The following is a description of a gene set: from publication Cui A, Huang T, Li S, Ma A, Pérez JL, Sander C, Keskin DB, Wu CJ, Fraenkel E, Hacohen N (PMID 38057668) Mouse Gene Set: CUI_TREG_IL18_RESPONSE_UP Cytokines mediate cell-cell communication in the immune system and represent important therapeutic targets. A myriad of studies have highlighted their central role in immune function, yet we lack a global view of the cellular responses of each immune cell type to each cytokine. To address this gap, the authors created the Immune Dictionary, a compendium of single-cell transcriptomic profiles of more than 17 immune cell types in response to each of 86 cytokines (>1,400 cytokine-cell type combinations) in mouse lymph nodes in vivo. A cytokine-centric view of the dictionary revealed that most cytokines induce highly cell-type-specific responses. For example, the inflammatory cytokine interleukin-1β induces distinct gene programmes in almost every cell type. A cell-type-centric view of the dictionary identified more than 66 cytokine-driven cellular polarization states across immune cell types, including previously uncharacterized states such as an interleukin-18-induced polyfunctional natural killer cell state. Genes positively differentially expressed in cell type: Treg upon treatment with cytokine: IL-18 in mouse lymph nodes in vivo. species: Mus musculus, and this is the list of marker genes: Hspa9, Dgat2, Rrs1, Irgm2, Mif, Ly6a, Isg20, Cetn3, Psma7, Slfn1, Gbp9, Batf, Ms4a4c, Zbp1, Igtp, Gimap4, Iigp1, Timm10, Bcl3, Nfkbia, Dtx3l, Psma4, Stat3, Gbp8, Ptpn1, Prdx2, Xaf1, Mrpl21, Dbnl, Rbmxl1, Mif4gd, Mrto4, Tapbp, Wdr18, Cyba, Tcof1, Psmb10, Parp9, Ube2l6, Ddx21, Psme2, Ifi27l2a, H2-K1, Psma2, Parp14, Serpina3g, Irf8, Gtpbp4, Ppp1r14b, Pim2, Ier5, Tomm20, Tuba4a, Gbp2, Tmem238, Utp18, Socs3, Gbp7, Psmb8, Nme1, Ncl, Stat1, Irgm1, Socs1, Nop56, Ifi206, Ebna1bp2, Nfkbie, Lgals3bp, Cct3, Ranbp1, Cd82, Cxcl10, Ltb, Tapbpl, Gbp4, Gpatch4, Lyar, Ftsj3, H2-Q7, Eif4a1, Ifit1, Ddx39a, Isg15 (ISG15 ubiquitin-like modifier), Bst2, Nhp2, Nsun2, Mrps34, Samhd1, Gbp6, Rnaseh2c, Snhg20, Fbl, H2-T23, Ifi47, Pa2g4, Erh, Irf1, Gbp3, Ppa1, Eif5a, Med11, Rexo2, Tnfrsf4, Hopx, Uchl3, Coq5, Lzic, Il1r2, Nampt, Ran (NCBI Gene Id 19384, RAN, member RAS oncogene family), Psmb9, Dctpp1, Npm1, Gbp5, Gadd45b, Plaat3, Psmb5, Psme1, Hspd1, Hspa4, Cct5, Znrd2, Anp32b, Tap2, Nmi, C1qbp, Rbx1, Prmt1, Sfxn1, Nlrc5, Icam1, B2m, H2-T22, Uqcc2, Apex1, Psma5 (NCBI Gene Id 26442), Tap1, Ifi35, Snrpa1, Ube2e1, Pim1, Fabp5, Rtp4, Mndal, Snrpd1, Alyref, Psmd6, Fas, Trim21, Sf3b3, Noc2l, Ly6e, Srm